Given this list of marker genes SFN, YWHAH, YWHAE, INSR, YWHAB, STXBP4, AKT2, PRKCI, PRKCZ, PPP1CC (NCBI Gene Id 5501), AKT1, TBC1D4, TRIP10, STX4, VAMP2, LNPEP (NCBI Gene Id 4012), ASIP, YWHAZ, GYS1, PPP1R3A, RHOQ, YWHAQ, YWHAG, GSK3B, SLC2A4, INS, here is a description of the gene set: studied in species Homo sapiens Human Gene Set: PID_INSULIN_GLUCOSE_PATHWAY from publication Schaefer CF, Anthony K, Krupa S, Buchoff J, Day M, Hannay T, Buetow KH (PMID 18832364) Insulin-mediated glucose transport